Given this list of marker genes MED14, SLF2, HEY2, SOBP, VAMP4, SRSF8, ARHGAP12, LNPK, ACVR1 (activin A receptor type 1), MIGA2, NABP1, SPTY2D1, FOXF2, ARHGEF11, PCDHA1, LAPTM4A, NBL1, MAP3K8, ZHX2, IGF2BP3, TIMP2, DENND10, USP32, KLF11, BHLHE41, MTMR4, AKT3, MAP7, KIF23, DDX11, TSPAN9, TEAD1, FOXG1 (NCBI Gene Id 2293), PTGFRN, LARP4, USP32P2, SUV39H1, PLEKHA3, HMGA2, MTLN, SMOC2, KDM2A, NBEA, PPP6R3, KCNQ2, KMT2D, RYR3, DDX5, RASL11B (RAS like family 11 member B), IKZF4, VANGL1, NPAS2, RB1, NHLH1, HPS5, CASP2, HOXB3, JAKMIP1, MAB21L1, PAFAH1B1 (platelet activating factor acetylhydrolase 1b regulatory subunit 1), SNX16, CLIP4, BTBD10, ELK3, LMX1A, SHANK2, SNX5, LCLAT1, HIVEP2, FJX1, SRSF2, ITCH, AFF4, CMPK1, SGMS1, FRMD6, STK17B, RSRP1, USP15, ROCK2 (NCBI Gene Id 9475), STAT3, EMX2, MAP3K2, CNOT7, RAB5B, ATG2A, AHCTF1, KMT5B, PLCB1, HIF1AN, EFL1, SLC4A7, GTPBP2, DCBLD2, COL19A1, ACTL6A, ACSL4, SELENOI, MACROD2 (mono-ADP ribosylhydrolase 2), PTPN2, ZDHHC1, CAMK2N2, CFL2, ATRN, WDR20, ZNFX1, SMAD7, PAPOLA, DNM2, ABHD3, NFIX (NCBI Gene Id 4784), MAPRE1, GOPC, TP63, KIAA0513, ZNF704, ZNF711, RAP2C, NR1D1, PCDHAC2, PKNOX1, TBX3, KCNN2 (NCBI Gene Id 3781), IGF2BP1, CDK2, PIK3R1, MASTL, WEE1, ZNF367, TRIM3, VLDLR, RASD1, NFAT5, RFX3, EIF4G2, PCDHA10, SOX5, CEP120, CDK2AP1, PCDHA9, ZDHHC9, PCDHA8, L3MBTL3 (L3MBTL histone methyl-lysine binding protein 3), SPOPL, SFMBT1, SLC24A4, KLF12, MAPRE3, PRR15, BNC2, DYRK1A, ZFC3H1, USP6, N4BP1, CELSR2, EFCAB14, PGM2L1, NETO2, GRM7, RAD52, SOX4, ZBTB4, MAP3K5, RBBP6, ABRAXAS2, RAB10, ADIPOR2, NF1, SERTAD2, VGLL3, ENPP5, CCDC88A, PCDHA12, MAP3K9 (mitogen-activated protein kinase kinase kinase 9), SKIDA1, PCDHA11, HAS2, SEMA4B, ZNF236, ERBIN, CCNJ, YTHDF2, HMGB3, MEX3D, PKIA, CALD1 (caldesmon 1), TNFRSF21, TAOK3, ARHGAP29, PURB, PKD2, RICTOR, DNAJB9, KLHL20, ARID4B, KCND2, HOXA3, FBXL5 (NCBI Gene Id 26234), PSD, RTN2, PCDHA7, NAA30, SACS, SNRK, TBC1D9, TMEM64, HOXD8, CELF2, SMC4, KBTBD2 (kelch repeat and BTB domain containing 2), ARID4A, ASAP2, ANKRD12, TMEM50B, ANKRD50, GNS, NSD2, CDC37L1, ZFAND4, WNK3, ZNF217, TSPYL2, CREB5, STX6, LAMP2, DDX3X, FOXA1, CNOT4, DUSP8, BTG3, PARD6B, ASF1A, CUL3, ZBTB46, TOPORS, AKAP13, TNFSF11, MYRF, OGT, BTBD7, SYT1, STC1, RAPGEF4, ZFYVE9, SH3PXD2A, ATG16L1, FAM78A, SH3BP5 (SH3 domain binding protein 5), DNAJB6, CEP97, MCM7, ANKRD29, SMAD5, NPAT, MFSD6, TMEM217, CSRNP3, SLAIN1, PCDHA13, E2F1, E2F7, PAK6, YES1, CACUL1, PTHLH, PFN2, TGFBR2, TRIOBP, KIF5A, PCDHA2, ARK2N, PCDHA5, BIRC6, NAA50, IKZF2, ABHD2, BMPR2, PCDHA6, PPP3CA, ARHGAP1, RNF31, TAF5L (TATA-box binding protein associated factor 5 like), SLC2A4RG, MIB1, NAGK, DPYSL2, FNBP1L, RBM33, NRP2 (neuropilin 2), ARHGAP35, EPC2, SYN2, MIER3, SOCS6, LRCH2, HYCC2, NKIRAS1, MAP4, MAP1B, ARHGAP24, GOSR1, CENPO, SRSF5, SPRY4, LRIG1, PDGFRA, MYB, EREG (epiregulin), SP3, ANKFY1, NHLH2 (NCBI Gene Id 90888), CACNB1, SRGAP3, DDX3Y, ZNF512B, CNOT6, PRKAA1, KPNA3, HBP1, NIPA1, CHD9, FGF9, BICD2, TBL1X, TNFSF12, AGO1 (NCBI Gene Id 26523), GRAMD1A, UBE3A, LPGAT1, TMEM168, MAPK6, NEUROG2, ERBB4, GBF1, PCDHA3, MMP14, MBNL1, DIP2A, NFIA, BCL2L2, PCDH20, STYX, PREX1, SLC1A2, MAP3K12, AFG1L, CDK12, ZFHX4, WDFY3, ATP2C1, PIGS, NEUROG1, ZFP91, SMOC1, DENND10P1, FCHO2, BRWD1 (NCBI Gene Id 54146), EFNB1, BLCAP, PCDHAC1 (protocadherin alpha subfamily C, 1), MECP2, ITPR1, M6PR, PANX2, CPEB2, C14orf28, CIC, UBR5, DNAJC16, PIGA, EPHA4, PPP1R21, BRMS1L, CEP57, TMEM127, FAM13A, SINHCAF, SKI, SORL1, BAHD1, ST8SIA2, HECA, SASH1, EPB41L4B, BTF3L4, FSTL5, NDEL1, IER3IP1, TENT5C, RORB, FBXW11, MAP3K3, PHTF2, GATAD2B, QKI, PUF60, PI4KB, PPP1R10, GDA, ZFPM2, TESK2, TNRC6A, SAMTOR, LIMK1, THRA, HABP4, GOLGA1, WDR1, ZBTB18, EMSY, DAZAP2 (NCBI Gene Id 9802), PPP6R2, ASXL2 (ASXL transcriptional regulator 2), KLF9, PTPRT, STK38 (serine/threonine kinase 38), POLQ, RTN1, GABBR2, CA10, MAPK4, FASTK, COL4A3, USP3, SCAMP2, MOB3B, SOX21, CSNK1G1, ATL3, KCNJ10, FOXJ3, HIF1A, PTPN4, SLITRK3, MAML1, SSH2, SLC40A1, SNIP1, IGF1, TSG101 (tumor susceptibility 101), APCDD1, PCDHA4, AKTIP, MYT1, LARP4B, SUMF1, R3HDM1, TNKS1BP1, SYBU (syntabulin), here is a description of the gene set: Human Gene Set: TGCACTT_MIR519C_MIR519B_MIR519A studied in species Homo sapiens Genes having at least one occurence of the motif TGCACTT in their 3' untranslated region. The motif represents putative target (that is, seed match) of human mature miRNAs hsa-miR-519c, hsa-miR-519b and hsa-miR-519a (v7.1 miRBase).